The following is a description of a gene set: Genes predicted to be targets of miRBase v22 microRNA mmu_miR_218_5p in miRDB v6.0 with MirTarget v4 prediction scores > 80 (high confidence targets). Mouse Gene Set: MIR_218_5P from publication Chen Y, Wang X (PMID 31504780) species: Mus musculus, and this is the list of marker genes: Arhgap15, Agap1, Jade3, Arf6, Gnb1, Camkk2 (NCBI Gene Id 207565), Kctd9, Pld5, Gnas, Ptprr, Ppargc1a, Fam241b, Hapln1, St8sia4, Cntn1, Tmed8, Pdgfra, Bpnt2, Nyap2, Epha5, Dbn1, Kcnh1, Sh3rf1, Gpr161, Rimbp2, Ccer2, Ptp4a1, Mbnl1, Cped1, Plekhg1, Mpzl2, Ccdc6 (NCBI Gene Id 76551), Sgpl1, Igsf11, Sorbs1, Ncan, Hivep1, Rnf41, Robo2, Rassf2, Dazap1, Nrxn3, Gucy1a2, Rgs17, Pum2, Scn2b, Glce, Herpud2, Pik3c2a, Lasp1 (NCBI Gene Id 16796), Ctnnd2, Ebf2, Plpp3, Chst8, Rnf103, Plxnc1, Plgrkt, Man2a1, Ugt8a, Ago2, Trarg1, Adgrb3, Fzd4, Daam1, Mdga1, Rnf139, Zeb2, Flrt3, Runx3, Dnal1, Fgf12, Kdm5a, Pcgf2, Sephs1, Dcun1d1, Pold3, Smchd1, Asic1, Sgcz, Plppr4, Sec61a1, Kcnj16, Mitf, Sntb2, Stam2, Cbx5, Serpini1, Zfp202, Shisa6, Rab3b, Tent5d, Msi2, Pcdh8, Lin28b, Cd200r1, Specc1l, Itm2c, Nlrp6, Larp4b, Brinp3, Pclo, Setbp1 (SET binding protein 1), B3gat2, Ikzf1, Dcbld2, Gria2, Chm, Lcorl (NCBI Gene Id 338482), Gfpt1, Cdc42se2, Syt13, Mvb12b, Pkp4, Dennd10, Ms4a6d, Ssr3, Ints14, Phc3, Abhd14a, Lrat, Rfx3, Bend3, Cilk1, Insyn2a, Reln, Hecw1, Mier3, Cd209a, Nepn, Zfp236, Ppp2r5a, Brcc3, Rhobtb1, Trim9, Ptpra, Piezo2, Sh3kbp1, Hp1bp3, Lgr4, Rorb, Otud7b, Hcfc1, Hcn3, Nsa2, Fam20b, Trhde, Eif2ak3, Parp12, Rcbtb1, Cntnap2, Shank2, Klf12 (NCBI Gene Id 78722), Nr1d2, Robo1, Nhsl3, Ripor2, Tmem132b, St18, Amotl1, Acsl1, Ret, Shoc2, Mfhas1, Zmiz1, Pdzd4, Clec2e, Npas2, Pex5l, Socs3, Fn1, Tmem151a, Fam3c, Sfxn5, Exd2, Tmx1, Nacc1, 2510009E07Rik, Slc16a7, Mbnl2, Jade2 (NCBI Gene Id 76901), Kif21b, Abcg4, Adgrl1, Eif5a2, Kirrel3, Slc1a2, Nup50, Purb, Snx18, Cacna1g, Cep55, Pcnp, Mid2, Rabgap1l, Wnt2b, Usp32, Golga7, Fbxo41, Insyn2b, Bcl11b, Rnf38, Bcl9, Rab33b, Tyw3, Prkg1 (protein kinase, cGMP-dependent, type I), Slc6a1, Anks1b, Zfp609, Rhoq, Gpr45, Tub, Sh2d1a (NCBI Gene Id 279676), Cdh8, Inhbb, Msl2, Sertad2, Sema6a, Thsd7a, Diras1, Slco5a1, Tmem25, Ano4, Pde12, Sv2a, Faap100, Rnf114, Slc66a3, Cul3 (cullin 3), Plekhf2, Klhl29, Plcxd2, Sorcs1, Cacybp (calcyclin binding protein), Nav3, Trpc3, Galnt13, Adipor2, Klhl13, Gabrb3, Myorg, Zfp654, Shc4, Rabep1, Mospd1, B3gat1, Zfx (zinc finger protein X-linked), Scgb1b24, Vat1, Micall1, Ebf3, Nectin1, Magi2, Ankrd27, Aif1l, Exo1 (NCBI Gene Id 70554), Wdr44, Hoxd10, Nmt2, Mdfic (MyoD family inhibitor domain containing), Ddx41, Extl3, Arpp19, Pheta1, Kalrn, Ube3a, Tanc2, Gnai2, Grm1, Lypd6b, Rara, Pbx2, Grik2, Ranbp10, Tspan5, Hs3st2, Napepld, Gskip, Yeats4, Nrcam, Kcnk1, Tbc1d8b, Ark2c, Sertad4, Gdpd5, Kcnip3, Ermp1, Naa15, Bicd1, Ddx5, Med17, Runx2, Kcnd2, Dlg2, Cttnbp2nl, Creb1, Cacna1i, Cert1, Bltp3b, Ppp4r2, Thoc2, Lmo7, Grip1, Pou2f1, Retnlg, Mdga2, Gramd4, Rab6a, Calcrl, Atosa, Gpr153, Col19a1, Mindy2, Jade1, Scai, Ubqln2, Mtmr1, Ell2, Cpne8, Mast4, Hlf, Tmem178, Ppp4r3b, Elfn2, Ube2h (ubiquitin-conjugating enzyme E2H), Hectd2, Satb2, Ccdc88a, Slc5a3, Anxa13, Fbxl14, Kcnb1, Fgd4, Snx4, Vopp1, Pi4k2a, Klf9, Bmi1 (Bmi1 polycomb ring finger oncogene), L3mbtl3, Onecut2, B3galt2, Serinc5, Ubr3, Zbtb11, Nsd3